The following is a description of a gene set: Any process that results in a change in state or activity of a cell (in terms of movement, secretion, enzyme production, gene expression, etc.) as a result of a nicotine stimulus. Human Gene Set: GOBP_CELLULAR_RESPONSE_TO_NICOTINE species: Homo sapiens, and this is the list of marker genes: MSX1, RELA, B2M, NTRK1, CHRNA2, NFKB1 (NCBI Gene Id 4790), BAD, TNF